Given this list of marker genes CDK20, CDK9, HBA2, LFNG, SMG1, HOXB5, FOXA1, MBD1, here is a description of the gene set: from publication Neben K, Schnittger S, Brors B, Tews B, Kokocinski F, Haferlach T, Müller J, Hahn M, Hiddemann W, Eils R, Lichter P, Schoch C (PMID 15674343) species: Homo sapiens In acute myeloid leukemia (AML), constitutive activation of the FLT3 receptor tyrosine kinase, either by internal tandem duplications (FLT3-ITD) of the juxtamembrane region or by point mutations in the second tyrosine kinase domain (FLT3-TKD), as well as point mutations of the NRAS gene (NRAS-PM) are among the most frequent somatic gene mutations. To elucidate whether these mutations cause aberrant signal transduction in AML, we used gene expression profiling in a series of 110 newly diagnosed AML patients with normal karyotype. The different algorithms used for data analysis revealed highly concordant sets of genes, indicating that the identified gene signatures are specific for each analysed subgroup. Whereas samples with FLT3-ITD and FLT3-TKD could be separated with up to 100% accuracy, this did not apply for NRAS-PM and wild-type samples, suggesting that only FLT3-ITD and FLT3-TKD are associated with an apparent signature in AML. The set of discriminating genes included several known genes, which are involved in cell cycle control (CDC14A, WEE1), gene transcription (HOXB5, FOXA1), and signal transduction (SMG1). In conclusion, we showed that unique gene expression patterns can be correlated with FLT3-ITD and FLT3-TKD. This might lead to the identification of further pathogenetic relevant candidate genes particularly in AML with normal karyotype. Human Gene Set: NEBEN_AML_WITH_FLT3_OR_NRAS_UP Genes up-regulated in acute myeloid leukemia (AML) samples with constitutively activated FLT3 or with activating point mutations within NRAS.